Given this list of marker genes DDX60, ZNF787, SYNE2, IFI44, CWC22, RBL1, IRF7, LIPA, BCL3, GABRG1, HOXD11, CENPF, GBP4, IRGM, HELZ2, GCH1, TRIM25 (tripartite motif containing 25), ISOC1, DHX58 (NCBI Gene Id 79132), ASB13, PARD6G, GRK1, EEIG1 (NCBI Gene Id 90676), DAXX, GADD45G, MORC3, N4BP1, RTP4, TCP10L (t-complex 10 like), RAB29, RIPK1, ADAR, STAT2, NOTCH1, TDRD7, SH3BP2, CMTM6, SHFL, ZUP1, TRAFD1, TMEM50B, SOCS3, ETS2, PARP12, CHMP4B, FHL2, ICAM1, FRMD6, ISG20, TASOR2, ARNT2, CRYBG1, MX2, RSAD2, REP15 (RAB15 effector protein), TAPBP, GBP2, NAMPT, MYD88, TMEM184B, CMPK2, LYZL4, TOR1AIP2, FGL2, PPA1, CHRDL1, LGALS3BP, VPS54 (VPS54 subunit of GARP complex), ANKFY1, IFIT2, ITIH1, COX18, RNF114, MOV10, GPSM2, RPS10, CASP2, IFI35, TLR7, GBP7, BHLHE22, TRIM26, UBE2D1, GP9, SLFN12L, ZNF281, TPST1, FAM111A, TMEM140, B3GNT5, IFIT1B, NUPR1, PEX26, CXCL10, GZMB, MVB12A, OASL, SLAIN1, PLEKHF2, CISH, CYYR1, TOR3A, RAPGEF6, IL13, STAT3, CCND2, MAP3K8, EPSTI1, CLIC4, USP18, MYOF, TRIM34, PML, PARP14, ZNFX1, ZBTB22, GPR87, TRAM2, SAMHD1, PIM2, FNBP4, RNF14, TTC39B, HOOK2, PNPT1, CEP68, ASB3, OAS2, MAP6, APOBEC3B, TAP1, CCRL2, SLFN13, HK1, TEX2, KLRK1, ISG15, WNT16, ELOVL6, APOBEC1, IRF1, OGFR, EFR3A, CNP, MX1, STAT1, PRKCQ, CD274, SOCS1, RNF19B, CDC42SE2, ANGPTL8, COL12A1, MTFR2, LGALS8, IFIT3, HAVCR1, IRF9, GMPPB, RBM43, RAD51AP1, TOR1AIP1, PSMB9, PSMB8, CHAD, MAP2K1, CASP4, CMTR1, IFIH1, HLA-E, GBP6, OGFRL1, PARP9, EIF2AK2, TRIM21, DAPP1, NUP153, PKD2L2, TNFSF10, NEFM, PSMB10, RIPK2, IL22, FRMD4B (FERM domain containing 4B), ETNK1, ARHGEF10, LY96, KBTBD2, KEAP1, C19orf12, OAS1, IRF4, EXO1, SLAMF1, DDX24, LYSMD2, SELP, PTTG1, ZBP1 (NCBI Gene Id 81030), AIDA, here is a description of the gene set: species: Homo sapiens Genes up-regulated in KLRG1- SELL low T reg: CD69- versus CD69+. from publication Cheng G, Yuan X, Tsai MS, Podack ER, Yu A, Malek TR (PMID 22786769) Thymic-derived natural T regulatory cells (nTregs) are characterized by functional and phenotypic heterogeneity. Recently, a small fraction of peripheral Tregs have been shown to express Klrg1, but it remains unclear the extent Klrg1 defines a unique Treg subset. Here we show that Klrg1+ Tregs represent a terminally differentiated Treg subset derived from Klrg1- Tregs. This subset is a recent antigen-responsive and a highly activated short-lived Treg population that expresses enhanced levels of Treg suppressive molecules and that preferentially resides within mucosal tissues. The development of Klrg1+ Tregs also requires extensive IL-2R signaling. This activity represents a distinct function for IL-2, independent from its contribution to Treg homeostasis and competitive fitness. These and other properties are analogous to terminally differentiated short-lived CD8+ T effector cells. Our findings suggest that an important pathway driving antigen-activated conventional T lymphocytes also operates for Tregs. Gene expression analysis was performed of this and other Treg subsets based on expression of CD62L, CD69, and Klrg1 to define the molecular properties of Klrg1+ Tregs and its relationship to other Treg subsets found in the peripheral immune tissues. Human Gene Set: GSE36527_CD69_NEG_VS_POS_TREG_CD62L_LOS_KLRG1_NEG_UP